The following is a description of a gene set: Mouse Gene Set: chr3C studied in species Mus musculus, and this is the list of marker genes: Or14m1-ps1, Gm2328, Gm22784 (predicted gene, 22784), Gm23891, Gm38247, Gm29230, Gm34303, Gm5274, 4931419H13Rik, Gm22480, Gm29741 (NCBI Gene Id 638779), Gm16206, Stoml3, Gm31026, Rpl23a-ps5, Ndufc1, 6430500D05Rik, Ccdc169, Gm10729, Mir6379, Gm8109, Gm31415, Gm2345, Gm2447, Ufm1, Mgarp, Gm7977, Gm30735, Naa15, Gm20557, Slc7a11, Mab21l1 (NCBI Gene Id 99871), Proser1 (NCBI Gene Id 72683), B020017C02Rik, Spart, 5830415G21Rik, Gm25132, C820005J03Rik, Nbea, 5031434O11Rik, Maml3, Pcdh18, Alg5, Cog6, Noct, Gm30173, Gm20750, C130089K02Rik, Sertm1, Gm6209, Gm10293, 4933417G07Rik, Lhfpl6, Setd7, Frem2, Trpc4, Gm9442, Gm6204, Postn, Gm20089, 1700018B24Rik, Supt20, 3110080O07Rik, Gm5641, 5430420F09Rik, Rab33b, Gm6073, Gm43471, Gm30292, Mgst2, Gm10730, Gm24851, Gm19817, Smad9, 4930577N17Rik, 5430433H01Rik, Foxo1, Nhlrc3, Rfxap, Gm24503, Gm43549, Gm38237, Gm18018, Gm10254, Ccna1, Gm5103, Gm5846, Sohlh2, Gm37548, Elf2, Dclk1, Gm9831, Gm10356, Exosc8, Gm2229, Gm23675